Given this list of marker genes Erlec1, Notum, P4hb, Psma1, Shh (NCBI Gene Id 20423), Psmd6, Dhh, Psmc5, Psmd13, Uba52, Psma3, Psmc6, Psma4, Psmb1, Scube2, Ubc, Psmd8, Ihh, Gpc5, Psmd12, Psmb7, Psmd2, Psmc3, Psma6 (NCBI Gene Id 26443), Psmc1, Sel1l, Disp2, Psmd11, Rps27a, Vcp, Os9, Psma7, Psma5, Psmb2, Derl2, Adrm1, Uba52rt, Psmd3, Syvn1, Psmd14, Psmc2, Psmd7, Hhat, Psmc4, Psmb6, Ubb, Psmd1, Psmb5, Psmb3, Psmb4, Psma2, here is a description of the gene set: Hedgehog ligand biogenesis species: Mus musculus Mouse Gene Set: REACTOME_HEDGEHOG_LIGAND_BIOGENESIS